The following is a description of a gene set: This event has been computationally inferred from an event that has been demonstrated in another species.<p>The inference is based on the homology mapping from PANTHER. Briefly, reactions for which all involved PhysicalEntities (in input, output and catalyst) have a mapped orthologue/paralogue (for complexes at least 75% of components must have a mapping) are inferred to the other species. Reactome Pathway: RHOQ GTPase cycle studied in species Mus musculus part of: RHO GTPase cycle electronically inferred by orthology from the curated human pathway, and this is the list of marker genes: Prex1, Arhgap26, Rab7, Depdc1b, Pak4 (NCBI Gene Id 70584), Wwp2, Vangl1, Gja1, Arhgap33, Arhgap17, Plekhg3, Itsn1, Mpp7, Jup, Lamtor1, Gopc, Steap3, Ophn1, Arhgef7, Gfod1, Trip10, Dlc1, Cdc42, Cav1